Given this list of marker genes Pik3r2, Irs1, Shc1, Alkal2, Ltk, Grb2, Pik3cb, here is a description of the gene set: Reactome Pathway: Signaling by LTK This event has been computationally inferred from an event that has been demonstrated in another species.<p>The inference is based on the homology mapping from PANTHER. Briefly, reactions for which all involved PhysicalEntities (in input, output and catalyst) have a mapped orthologue/paralogue (for complexes at least 75% of components must have a mapping) are inferred to the other species. electronically inferred by orthology from the curated human pathway part of: Signaling by Receptor Tyrosine Kinases species: Mus musculus